Given this list of marker genes PMF1, SPC25, BIRC5, AURKB, SPC24, INCENP, ZWINT, NSL1, CENPT, CDCA8, DSN1, KNL1, CENPW, NUF2, MIS12, NDC80, CENPX, CENPC, CENPS, here is a description of the gene set: Human Gene Set: KEGG_MEDICUS_REFERENCE_ORGANIZATION_OF_THE_OUTER_KINETOCHORE Organization of the outer kinetochore. Pathway ID: N01526. Pathway type: Reference. Pathway class: nt06515 Regulation of kinetochore-microtubule interactions. studied in species Homo sapiens Pathway Definition from KEGG: CPC == CENPC == MIS12C+KNL1C+CENP-TWSX -> CPC+CENPC+MIS12C+KNLC == CENP-TWSX == NDC80C